Given this list of marker genes 6430571L13Rik, Hat1, Ppp3ca, Ssx2ip, Kif3a, Cdk12, Cnpy1, Atp6v0a2, Adgrf2, Oprk1, Resf1, Fut10, Mfsd4a, Nipal4, Plekhh1, Eif4e3, Gemin5, Med27, Bag3, Krit1, 0610040J01Rik, Dazap1, Kdm7a, Idi1, Rps15a, Efcab14, Tenm3, Tfb2m, Zbtb41, Phactr4, Surf4, Rps6kb1, Zfp560, Cldn6, Blnk, Tmem170b, Uvssa, Igf2bp3, Zfp719, Zc3h6, Prpf40a, Dnajc19, Csde1, Ncl, Klf8 (Kruppel-like transcription factor 8), Ostn, Itpripl1, Tnrc6b (trinucleotide repeat containing 6b), Zfp281, Ppp1r15b, Snai2, Phf20l1, Tmem167b, Sass6, Mrps24, Ube2v2, Uevld, Atxn7, Epb41l5, Mapk8 (NCBI Gene Id 26419), Or7e176, Car8, Mapre1, Rdh16, Lrp2, Asap2, Atl3, Bdnf, Ubxn2a, Yipf5, Relch, Rorb, Adamdec1, Appl1, Zfp446, Ppih, Efnb1, Abraxas2, Actmap, Prune1, Cracd, Gk, Spam1, Cbx5, Ppp4c, Ucp1, Kalrn, Usp33, Ttll1, Lats1, Msl3, Gtpbp10, Mdm4, Zfp422, Wtap, Pgm3, Noc3l, Zcchc14, L3mbtl2 (NCBI Gene Id 214669), Ap1g1, Neurod4, Ctsa, Tra2b, Eda2r, Vhl, Gal3st3, Fsd1l, Dync2i1, Nip7, Tbc1d32, Kmt5b, Ccdc127, Tpbg, Mmachc, Psmd9, Hapln2, Tmem87a (NCBI Gene Id 211499), Cd164, Fam199x, Gja1, Ccar1, Spink5, Lin52, Zfp1006, Pik3ca, Tmem263, Col8a1, Mlph, Pip5k1c, Cited2, Nop9, Arap2, Slc35b3, Cdk7, Leng8, Rlim, Mrpl45, Ppp4r3b, Klf9, Hsf3, Bpnt2, Hnrnpf (NCBI Gene Id 98758), Gabpa, Pcdhb4, Topors, Reps2, Commd8, Fbxo27, Vps26a, Tut7, Ldhc, Wdr37, Plagl1, Decr2, Pxmp4, Fnbp4, Vcpkmt (NCBI Gene Id 207965), Tulp2, Topbp1, Ap2a2, Fbxl14, Slc16a9, Atad5, Cadm2, Isl1, Sp9, Larp4, Ptges3, Edaradd, Dscaml1, Ghitm (NCBI Gene Id 66092), Dnal1, Sirt6, Klf6, Jak2, Ammecr1l, P2ry10b, Hsdl1, Krtap3-1, Diaph2, Bmal2, Acot2, Lrrn4cl, Uhrf1, Ipmk, Mapk1ip1l, Rbfox2, Orc2, Zbtb24, Ncam1, Hspb3, Rigi, Slc35e1 (solute carrier family 35, member E1), Zfp770, Plcl1, Hapln1, Eif4e (NCBI Gene Id 668879), Snip1, Shh, Zfp865, Usp7, Lrat, Tasor, Cfl2, Nab1, Nbeal1, Sh3glb1, Cyp1a2, Abcb10, Samd3, Phtf2, Ildr2, Tab3, Or2ag2b, Xpo1, Ric3, Glt8d1, Pgr, Creb1, Ythdf3, Cdkn2aip, Ppfia3, Rtkn2, Mobp, Nap1l1, Rufy2, Dbr1, C5ar2, Ltn1, Arhgap35, Ttyh2, Kbtbd11, Tgfbr1, Wdfy1, Cep97 (NCBI Gene Id 74379), Zfp788, Car5b, Atp6v1g1, Togaram1, Gpr176, Nav1, Tbl1xr1, Hhat, Pvr, Dcun1d1, Samd8, Lonrf2, Mylk4, Znrf3, Per3, Coa3, Slain1, Eef1a1, Vps13c (NCBI Gene Id 97581), Olr1, Sdf2l1, Tmem175, Fbp1, Ifi213, Elovl5, Krr1, Kdelr2, Mllt10, Sgcb, Csk, Polr3gl, Svbp, Dmac1, Nol4, Edem1, Map2k6, Svs6, Clic5, Dzip1l, Entpd7 (NCBI Gene Id 93685), F2rl2, Rfx8, Ubr1, Cacna1d, Arfip1, Dclk1, Sike1, Eral1, Hmbox1, Btg1 (NCBI Gene Id 380657), Spib, Phf14, Ssbp2, Kpna3, 1700066M21Rik, Mga, Il27ra, Krt2, Ammecr1, Tenm2, Slc5a3, Peli2, Krt222, Rc3h2, Elavl2, Rab1a, Hdac8, Wnk3, Speer4f1, Vldlr, Naa40, Sprr2a2, Aftph, Cnot6l, Steap2, Cebpb, Cyld, Cd300a, Cstf2t, Tenm4, Tmem33 (NCBI Gene Id 78493), Eef1d, Micos10, Ube3a, Tnfrsf9, Nabp1, Col25a1, Pter, Dr1 (NCBI Gene Id 67362), C5ar1, Ube2k, Wdr44, Zfp345, Kdm1a, Fkbp3, Cd226, Fgf14, Ryr2, Kctd9, Dnajc18, Rab11fip1, Cep126, Pank3, Wdr31, Arpc3, Ubap1, Ebf2, Tef, Zfp574, Foxr1, Adra2b, Syn3, Heatr3, Sprr2a1, Mapk13, Slc35a5, Pdik1l, Brd2, Sgo1, Wdr82, Jcad, Patj, Ppm1e, Tafazzin, Edem2, Abhd5, Gpr157, Prkacb, Foxp2, Csgalnact2, Iws1, Agpat1, Akr1d1, Fgf12, Rfxank, Dmrta1, Insr, Soat1, here is a description of the gene set: Genes predicted to be targets of miRBase v22 microRNA mmu_miR_294_5p in miRDB v6.0 with MirTarget v4 prediction scores > 80 (high confidence targets). from publication Chen Y, Wang X (PMID 31504780) Mouse Gene Set: MIR_294_5P studied in species Mus musculus